The following is a description of a gene set: Neutrophil abscess formation is critical in innate immunity against many pathogens. Here, the mechanism of neutrophil abscess formation was investigated using a mouse model of Staphylococcus aureus cutaneous infection. Gene expression analysis of S. aureus-infected skin revealed that induction of neutrophil recruitment genes was largely dependent upon IL-1beta/IL-1R activation. Unexpectedly, using IL 1beta reporter mice, neutrophils were identified as the primary source of IL-1beta at the site of infection. Furthermore, IL-1beta-producing neutrophils were necessary and sufficient for abscess formation and bacterial clearance. S. aureus-induced IL 1beta production by neutrophils required TLR2, NOD2, FPRs and the ASC/NLRP3 inflammasome. Taken together, IL-1beta and neutrophil abscess formation during an infection are functionally, spatially and temporally linked as a consequence of direct IL-1beta production by neutrophils. Human Gene Set: GSE36826_WT_VS_IL1R_KO_SKIN_DN Genes down-regulated in skin: wildtype versus IL1R1 knockout. species: Homo sapiens from publication Cho JS, Guo Y, Ramos RI, Hebroni F, Plaisier SB, Xuan C, Granick JL, Matsushima H, Takashima A, Iwakura Y, Cheung AL, Cheng G, Lee DJ, Simon SI, Miller LS (PMID 23209417), and this is the list of marker genes: ANPEP, BCCIP, AARS1, POLDIP3, DSE, HSBP1, QPCT, ORAI2, CFP, PSMA1, VEGFA, SH3BGRL3, TREM1, HNRNPR, PFKP, EBLN2, IDO1, FPR1, CD101, MCL1 (NCBI Gene Id 4170), PPP1R15A (protein phosphatase 1 regulatory subunit 15A), ARF5, LFNG, EIF6, PREB, GNB1, UBE2A, NAB1, AATF, C5AR1, APOBEC3A, SNRPB, FRY, SLC25A37, VCAN, VIM, FLNA, GADD45GIP1, DDX21, PPP1CB, CHTOP, HCP5, AKR1C2, SLC3A2, IGF2BP2, LORICRIN, DDX39A, ALCAM, ILF2 (interleukin enhancer binding factor 2), TES, YIF1A, SYNGR3, TNFRSF11A, RPA4, PABPN1, KHNYN (NCBI Gene Id 23351), PITPNA, AQP9 (aquaporin 9), CD53, MAMLD1, DIDO1, DIAPH1, LAD1, PSMA5, STARD5, IGSF3, H2AC13, PSME3, RFTN1, TMEM43, LCP1, LRP8, CEP43, ZNF207, NSD3, MSC, BACH1, IRF4, AFTPH (NCBI Gene Id 54812), CDK2AP2, ZDHHC13, PDLIM7, COX7A2, OLR1, ACOT9, HCLS1, MYCL, TJAP1, ITGAE, THBS1, DUSP1, MTF1, LST1, STK38L, PPM1F, GNG11, EMCN, RHOG, ABCE1 (ATP binding cassette subfamily E member 1), H3-3B, PPP1R14B, S100A10, ACVR2A, ACLY, S100A12, HNRNPA2B1, MSN, IGFBP1, BAX, CDC42, RBM14, IKBKG, EIF4G2, PDE4A, SLC16A6, PACSIN2, EMP3, RNPS1, PPBP, CD5, SPEN, CDK14, SRF, DPH2, H2BC21, GPATCH2L (NCBI Gene Id 82392), TCIRG1, CGGBP1, TXNDC15, COTL1, GDI1, CYTIP, LDHA, PTBP1, SETD1B, LAMP3, TMEM214, POTEKP, KCNN4, VCP, ELMO3, NHP2, CD58, C15orf39, PTGS1, SRSF10, ADSS2, KAT6A, PSMD11, GNA15, CSF2RA, DPYS, EMC6, FHOD1, PARK7, PF4, DERL1, DNAJB5, TRA2A, PNP (purine nucleoside phosphorylase), H2AC6, AKAP17A, SGCB, CRIP1, CDKN1A, HMGN4, DGKA, S100A6, HNRNPM, TRAF1, S100P, EMP1, SPN (sialophorin), IDS, ZNF614, SFT2D2, CCR5, KIFC3, DAZAP1, BUB3, DUSP6, CSNK2A1 (casein kinase 2 alpha 1), SLC7A11, MAPKAPK3, MCUB, CST6, CST7, PID1, DDA1, REL, MGAT2, PTPN6, GCLC, ACTB, SCAF4, TFE3, NAMPT, SLC35B1 (solute carrier family 35 member B1)